Given this list of marker genes ZNHIT1, GLG1, URI1, DNPEP, DPM1, COX7A2L, EIF2B2, ARCN1, COPS6, HADHB (hydroxyacyl-CoA dehydrogenase trifunctional multienzyme complex subunit beta), NUBP1, COIL, RAF1, UBR5, TIAL1, PSMB4, ATP5MF, TOR1A, TPR, PSMC2, XPC, DDB2, CNBP, IK, RAD23B, UBA1, HTATSF1, SARS1, PPP1R7 (protein phosphatase 1 regulatory subunit 7), RAB1A, ZZZ3 (zinc finger ZZ-type containing 3), RAC1, HUWE1, CAPZB, PRKAR1A, BLCAP, CANX, CUX1, CLN3, VGLL4 (NCBI Gene Id 9686), UBE2A, ARF5, SDHA, ARPC4, PDAP1, COPS5, ATP6V1F, POR, FAF2, ILVBL, GATD3, RAB11A, YWHAB, OTUB1, WIPI2, METAP1, PEX11B, COX5A, PRPSAP1, SNW1, DRG1, here is a description of the gene set: Human Gene Set: MORF_XPC Neighborhood of XPC studied in species Homo sapiens Neighborhood of XPC xeroderma pigmentosum, complementation group C in the MORF expression compendium